Given this list of marker genes CXCR2, CCR2, CCR4, CCR10, CCR1, CXCR3, XCR1, GPR17, CCR5, CCR9, CXCR5, CXCR6, CXCR1, ACKR2, CCR3, GPR75, CCRL2, CCR7, ACKR4, CX3CR1, ACKR3, CCR6, CCR8, CMKLR1, CXCR4, GPR35, here is a description of the gene set: species: Homo sapiens Combining with a chemoattractant and transmitting the signal across the membrane by activating an associated G-protein; promotes the exchange of GDP for GTP on the alpha subunit of a heterotrimeric G-protein complex. Human Gene Set: GOMF_G_PROTEIN_COUPLED_CHEMOATTRACTANT_RECEPTOR_ACTIVITY